Given this list of marker genes Pgm2l1, Kat2b, Map6d1, Pcdha4, Hlf, Wfs1, Uri1 (NCBI Gene Id 97390), Tspan9, Dennd5b, Eif4a2, Zfp661, Smyd1, Ppp1r3b, Nek9, Frmd6, Slc22a23, Atl3, Ankrd13c, Zfp236, Ano5, Atad2, Mink1, Xrn1, Acer2, Fastk, Lima1, Retreg3, Ormdl3, Pcdha3, Gpr137c, Slc18a2, Ano3, Egln3, Cast, Cnot7, Ankrd33b, Arhgap35, Zbtb41, Chmp4c, Hook3, Zc3h12c, Pcsk5, Klhl28, Polr3g, Akap13, Aktip, Rps6ka5 (NCBI Gene Id 73086), Srgap1, Fcho2, Adam9, Smoc1, Dock4, 6430548M08Rik, Gpr137b, Mospd2, Pcdhac1, Vangl1, Zfp827, St6galnac6, E2f1, Tmem267, Ube3c, App, Nbea, Trappc14, Panx2, Gramd1a, Pdgfra, Vash2, Ccdc71l (coiled-coil domain containing 71 like), Mapk4, Ints14, Arhgef18, Slc31a2, Dsg4, Map3k2, Lhx6, Wdr37, Bcl11b, Hs3st5, Ppp1r15b, Bnip2, Ahnak, Ogfod2 (2-oxoglutarate and iron-dependent oxygenase domain containing 2), Trip11, Sumf1, Cd69, Sall1 (spalt like transcription factor 1), Nrip3, Irf2bp2, Kcnk10, Fzd3, Arhgef11, Enpp5, Rab22a, Mtmr3, Osr1, Purb, Rab33b, Smoc2, Sash1, Mapre3, Chd9, Ginm1, Ptpn3, Bbx, 2510009E07Rik, Nup35, Ezh1, Plekha7, Sybu, Rgmb, Nr4a3, Tmcc3, Pgbd5, Mkrn1, Idua, Dpysl2, Zdhhc1, Pthlh, Sh3pxd2a, Reps2, Crk, Nfat5, Myt1l, Klf9, Retreg2, Nabp1, Mcl1, Plxdc2, Tasor, Zfp9, Hycc2, Mylip, Snx8, Mfap3l (microfibrillar-associated protein 3-like), Glis3, Smim5, Osm, Rps6ka1, Med12l, Dcbld2, Afg1l, Cdca7, Uevld, Tfb2m, Cep97, Prr15 (proline rich 15), Rbbp7, Slc24a2, Fbxo28, Oxr1 (NCBI Gene Id 74830), Tgfbr2, Trpv6, Pfkp, Sema4b, Slc49a4, Dmtf1, Map7, Fbxl5, Sema7a, Camk2n2, Bahd1, U2surp, Map3k14, Sqstm1, Bicd2, Kif3b, Septin2, Kmt2b, Prrg1, Dennd10, Arhgap12, Gid4, Sar1b, Ankrd17, Ppp1r21, Crybg3 (beta-gamma crystallin domain containing 3), Suco (SUN domain containing ossification factor), Fat4, Frs2 (fibroblast growth factor receptor substrate 2), Brms1l, Tbcel, Pcdha10, Prepl, Sos1, Csnk1g1, Rest (NCBI Gene Id 72127), Derl2, Lama3, Slc17a8, Trim3, Fjx1, Rs1, E2f5, Ythdf3, St8sia2, Pkn2, Pcdha1, Pafah1b1, St3gal1, Rsrp1, Col4a4, Tbc1d8b, Mex3d, Zbtb4, Pcdha9, Mastl, Camta2, Flt1, Zhx2, Pcdha11, Ube2q2, Fnbp1l, Laptm4a, Nckap5, Jpt1, Unk, Csrnp3, Mfn2, Tph1 (tryptophan hydroxylase 1), Gxylt1, Map3k13, Tbc1d12, Foxj3, 1600012H06Rik, Kcnb1, Unkl, Pdcd1lg2, Slc16a6, Slc17a7, Luzp1, Tars2, Lrch1, Tet1, Stxbp5, Trappc2, Ism2, Arhgef10, Zfp367, Hbp1, Susd6, Arid4b, Rab10, Tbc1d9, Il25, Ptpn21, Pak5, Ccng2, Tmed8, Slc25a40, Ssh2, Cbln4, Fam219b (NCBI Gene Id 78323), Usp46 (NCBI Gene Id 69727), Zfp512b, Ulk1, Ago1, Fsd1l, Atg14, Iqsec2, Marchf8, Klf11, Psd, Mosmo, Pitpna, Cep120, Rnf2, Fat2, Bmpr2, Irf9, Dab2, Rbl2, Zbtb18, Ndel1, M6pr, Creb5, Kmt2a, Timp2, Pcdha5, Limk1, Rab5b, Skor1, Pbx3, Rcan3, Cmpk1, Coro2b, Itgb8, Reep3, Midn (midnolin), Spopl, Rasgrf2 (NCBI Gene Id 70739), Rap2c, St6galnac3, Btg3, Ankib1, Epha7, Nedd4l, Rasd1, Mier1 (NCBI Gene Id 76018), Fam13c, Srpk2, Rasl11b, C2cd2, Sorl1, Eri1, Map3k8, Rb1cc1, Btbd10, Heg1, Ankrd52, Tsg101, Usp32, Elk3, Rnf150, Zfp800, Zfyve26, Prr14l, Fgd5, Rgs17, Sh3bp2, Ppp1r3e, Dusp2, Nanos1, Cfl2, Abcg4, Spred1, Scn1a, Sall3, Unc80, Tnks2, Sobp, Npat, Rassf2, Pde3b, Fyco1, Armc8, Ddhd1, Agfg2, Epha4, Phip, Gab1, Rab11fip5, Ddhd2, Jazf1, Olfm1, Pls1, Usp24, Pcdha8, Myf5, Lpgat1, Rhoc, Naa30, B3galt2, Rab30, Pxk (PX domain containing serine/threonine kinase), Gabbr2, Apcdd1, Ncoa3, Atxn1l, Mmp24, Abca1, Cc2d1a, Slc16a9, Itpripl2, Lypd6, Gpr63, Cep57, Tnks1bp1, Pcdha12, Rab8b, Nagk, Clock, Bnc2, Rsbn1 (NCBI Gene Id 229675), Gosr1, Znfx1, Txnip, Pcdha6, Chrm2, Clip4, Smad5, Rnf6, Tmem127, Zfand4, Ankrd9, Gpc6, Ptchd4, Gon4l, Lrp8, Tle4, Trim36, Rp2, Acsl4, Pcdhac2, Nr2c2, Kif5a, Usp3, Rb1, Zfpm2, Mknk2, Pkd1, Pkd2, Napepld, Kcnq2, Cnot6l, Zfp91, Dpysl5, Zdhhc8, Kdm2a, Tanc2, Zfp704, Ugdh, Has2, Slc40a1 (solute carrier family 40 (iron-regulated transporter), member 1), Slc12a7 (solute carrier family 12, member 7), Ahrr, Kif23, Ntng1, Zbtb9, Aak1, Plekha3, Dnajc24, Zfp148, Ptpn4, Tmem64, Arhgap1, Tafa1, Slc2a4 (NCBI Gene Id 20528), Pex5l (peroxisomal biogenesis factor 5-like), Col4a3, Rundc1, Atxn7l1, Sertad2, Rufy2, Kpna2, Rnf128, Tnfaip1, Dnal1, Rgma, Neurog3, F3, Creb1, Crot, Rapgefl1, Npas2, Pkd2l2, Atg16l1, Tnfrsf21, Snx16, Pcdha2, Srcin1, Fibin, Tiam1, Fgd4, Sfmbt1, Akt3, S1pr1, Wdfy3, Arhgap26, Ldlrap1, Map3k12, Stx6, Rps6ka4, Trip10, Topors, Lrrc55, Pcdha7, here is a description of the gene set: species: Mus musculus Mouse Gene Set: MIR_20B_5P from publication Chen Y, Wang X (PMID 31504780) Genes predicted to be targets of miRBase v22 microRNA mmu_miR_20b_5p in miRDB v6.0 with MirTarget v4 prediction scores > 80 (high confidence targets).